Given this list of marker genes VRK1, PRKDC, BAZ1B, ATR, ATM, here is a description of the gene set: Catalysis of the transfer of a phosphate group to a histone variant H2AX. Human Gene Set: GOMF_HISTONE_H2AX_KINASE_ACTIVITY species: Homo sapiens